Given this list of marker genes Plin2, Clic1, Rbms2, Sema3f, Acp2, Plac8, Utrn, Ifi30, Tuba8, Dab2, Retreg1, Adrb2 (NCBI Gene Id 269028), Ly6a, Klf4, Capg, Arhgef2, Lamc2, Igfbp4, Ott, Lasp1, Vamp5, Sema3c, Avpi1, Gstm1, Stat6, Tm2d2, Abcc1, Nrbp2, Tmem45a, Lypla1, Col5a2, Snapc2, Prss23, Myzap, Acyp2 (acylphosphatase 2, muscle type), Dgcr6, Rhoa, Timp3, Dipk2a, Pltp, Klk8, Tead4, Adra2b, Ccn2, Mea1, Dbndd2, Bhlhe40, Ces2g, Gamt, Anxa11 (NCBI Gene Id 353076), Tns2 (tensin 2), S100a1 (S100 calcium binding protein A1), Papss2, Rnase4, Rnf13, Serpinb6a, Abhd8, Nfe2l1 (NCBI Gene Id 18023), Klf2, Map1lc3b, Nfic, Bbln, Snx10, Eno3, Phlda3, Fxyd5, Qki, H2bc4 (H2B clustered histone 4), Msln, Vps26c, Asns, Cyp51, Ebf3, Baiap2, Sec14l1, Atp6v0b, Ndrg4, Col4a1, Rhox5, Col4a2, Cyb5b, Guk1, Cd34, Slc1a5, Tnxb, Gas7, Anxa4, S100a13, Anxa8, Pkp2, Slc29a1, Ctla2a, Card19, Rflnb, Asah1, Nupr1, Fhl1, Tob1, Fzd2, Ica1, Lgals9, AU021092, Slc66a3, Nmt1, Acot7, Csrp1, Agrn, Carhsp1, Gipc1, Nedd9, Bag2, Akap12, Cd9, Tmem43, Trak1, Tram1, Pnpla2, Ldaf1, Map6, Fbn1, Aqp1, Ddr2, Dusp1, Trib3, Skap2, Sri, Cyb5r1 (cytochrome b5 reductase 1), Csnk2a1, Myo1c, Dap, Rnpepl1, Aldh2, Taldo1, Clic4, Pnkd, Mgst3, Galk1, Eln, Ly6c1, Clec3b, Fhl2, Tspo, Naa38, Trim47, Adm, Emp3, Gpc1, Ctla2b, Itgb4 (NCBI Gene Id 217330), Plekha7, Pold4, Eif4ebp1, Nppb, Tmbim1, Slc35e4, Cd151, Ero1a, Wwp2, here is a description of the gene set: species: Mus musculus Genes down-regulated in reverted NIH3T3 cells (fibroblasts transformed by activated KRAS which then reverted to normal cells upon stable over-expression of a dominant negative form of CDC25) vs normal fibroblasts. from publication Chiaradonna F, Sacco E, Manzoni R, Giorgio M, Vanoni M, Alberghina L (PMID 16607279) Mouse Gene Set: CHIARADONNA_NEOPLASTIC_TRANSFORMATION_CDC25_DN Mutational activation of ras genes is required for the onset and maintenance of different malignancies. Here we show, using a combination of molecular physiology, nutritional perturbations and transcriptional profiling, that full penetrance of phenotypes related to oncogenic Ras activation, including the shift of carbon metabolism towards fermentation and upregulation of key cell cycle regulators, is dependent upon glucose availability. These responses are induced by Ras activation, being specifically reverted by downregulation of the Ras pathway obtained through the expression of a dominant-negative Ras-specific guanine nucleotide exchange protein. Our data allow to link directly to ras activation the alteration in energy metabolism of cancer cells, their fragility towards glucose shortage and ensuing apoptotic death.